The following is a description of a gene set: Mouse Gene Set: GOBP_REGULATION_OF_TYPE_2_MITOPHAGY Any process that modulates the frequency, rate or extent of type 2 mitophagy. species: Mus musculus, and this is the list of marker genes: Prkn (parkin RBR E3 ubiquitin protein ligase), Mul1, Hdac6 (NCBI Gene Id 20374), Atp5if1, Tomm7 (translocase of outer mitochondrial membrane 7), Vdac1, Pink1, Vps13c (vacuolar protein sorting 13C), Htra2, Hk2, Cdc37, Gba1, Huwe1